The following is a description of a gene set: species: Homo sapiens Dendritic cells (DCs) in lymphoid tissue comprise conventional DCs (cDCs) and plasmacytoid DCs (pDCs) that develop from common DC progenitors (CDPs). CDPs are Flt3+c-kitintM-CSFR+ and reside in bone marrow. Here we describe a two-step culture system that recapitulates DC development from c-kithiFlt3-/lo multipotent progenitors (MPPs) into CDPs and further into cDC and pDC subsets. MPPs and CDPs are amplified in vitro with Flt3 ligand, stem cell factor, hyper-IL-6 and insulin- like growth factor-1. The four-factor cocktail readily induces self-renewal of MPPs and their progression into CDPs and has no self-renewal activity on CDPs. The amplified CDPs respond to all known DC poietins and generate all lymphoid tissue DCs in vivo and in vitro. Additionally, in vitro CDPs recapitulate the cell surface marker and gene expression profile of in vivo CDPs and possess a DC-primed transcription profile. Transforming growth factor-β1 (TGF-β1) impacts on CDPs and directs their differentiation towards cDCs. Genome-wide gene expression profiling of TGF-β1-induced genes identified transcription factors, such as interferon regulatory factor-4 (IRF-4) and RelB, that are implicated as instructive factors for cDC subset specification. TGF-β1 also induced the transcription factor inhibitor of differentiation/DNA binding 2 (Id2) that suppresses pDC development. Thus, TGF-β1 directs CDP differentiation into cDC by inducing both cDC instructive factors and pDC inhibitory factors. Genes up-regulated in amplified multipotent progenitors versus common dendritic cells. from publication Felker P, Seré K, Lin Q, Becker C, Hristov M, Hieronymus T, Zenke M (PMID 20881193) Human Gene Set: GSE22432_MULTIPOTENT_PROGENITOR_VS_CDC_UP, and this is the list of marker genes: RBP1, TNP1, MYOG, LY86, IL12RB2, DEPP1, PPP1R1B, SLFN5, TEX48, KCNU1, KRTAP15-1, HLTF, SPHK2, IFI27L2, FBXO7, FHL5, ALDH1B1, SLAMF8, TENT4A, TWSG1, GZMH, PRSS58, NPC2, SLC26A4, PIK3IP1, AMN1, TMOD3, LEMD2, DRGX, SLC28A2 (NCBI Gene Id 9153), GEM, SNRPN, PNMA8A, PBLD, ARID5B, COL4A2, HOXD9, ZNF260, PIEZO2, PCGF1, BST2, TAL1, FUT2, MAFK, PMP2, SAMHD1 (SAM and HD domain containing deoxynucleoside triphosphate triphosphohydrolase 1), MAML1 (NCBI Gene Id 9794), TM6SF2 (transmembrane 6 superfamily member 2), TREML2, RAB29, POU2F2, ANXA7, FAS, ASAH2, WASHC4, RASA4, NACAD, GAS6, ACSL1, SH2D1A, MX2, C15orf62, PLEKHG1, GPC1, CSRNP1, ADPRHL1, OS9, PER2, RNASEL, PROX2, TRAFD1, TENT2, EBI3, GPR20, SPAG6, MPP2, BCAR1, LY6E, PANK2, CHMP4B, SPPL2A, ZNF76, SPINK4, TFG, PEBP4, ZBTB24, GBP7, KLHL24, GRAP, NEGR1, MYL3, MARK4, RALA, BARHL2, CHD4 (NCBI Gene Id 1108), GCH1, UBE2Z, KANK2, TSPAN1, BFAR, FBXL12, FGF10, PHLDA2, MYH6, PHOX2A, PLEKHH1, TMPRSS11E, RNF115, NPR2, NUPR1, NONO, AKAP3, ADCK2, UFSP1, SLC6A6, ENDOD1, NBEA, FNDC4, PDE11A (phosphodiesterase 11A), SLC7A11 (NCBI Gene Id 23657), WNT2B, HBA2, SSTR3, RBMS2, LY6D, DPY19L1, DYNC1I2, DSC2, ARFGEF1, F2RL1, TENT5A, DCAKD, PLCB1, LMO2, GBP4, PSME2, DENND1A, DDHD1, ADGRV1, NEUROG3, DOC2A, SLFN13, ELF4, IRF9, HERC3, DDX24, CLEC4F, SLC18A1, PACSIN3, RPE, CD180, TLR3, PLCL2, PPP1R11, ST8SIA5, PML, DPF2, LRRC41, NPEPPS, USP25, DYNLRB2, ACAA1, TAP1, EFCAB12, VWC2, MIR99AHG, DHTKD1, SUDS3, REP15, MXD3, IQCK (NCBI Gene Id 124152), GAST, PNMA2, PLAAT3, RGS7, NEK7, BRD2, CTSO, PELI1, CCND1, TCAF2, DPM3, GALR2, HLA-E, FAM81A, TPST1 (tyrosylprotein sulfotransferase 1), CSNK1D, SLC7A8, COA5, AP2B1, NPAS1, SLC2A4, CST7, SLC35F1, DGKA, MLKL, PSME1 (NCBI Gene Id 5720), CXCR6, IFIH1